Given this list of marker genes ACSM2B, ACSM1 (acyl-CoA synthetase medium chain family member 1), GLYATL1, GLYAT, GLYATL3, GLYATL2, here is a description of the gene set: species: Homo sapiens Benzoic acid, widely used as a food preservative, is converted to hippuric acid by activation and conjugation with glycine. This was one of the first detoxification pathways discovered, and was formerly exploited clinically as an alternative means of nitrogen excretion in patients with urea cycle defects. Reactome Pathway: Conjugation of benzoate with glycine part of: Conjugation of carboxylic acids